The following is a description of a gene set: Human Gene Set: HP_HYPOTHALAMIC_HAMARTOMA The presence of a hamartoma of the hypothalamus. studied in species Homo sapiens Hypothalamic hamartoma, and this is the list of marker genes: VPS16, TOPORS, TMEM231, CPLANE1, GLI3, TIAM1, KIAA0753, SIX6, SOX2, OFD1, MAN2C1, KIF7, PDE6D, SMO, FAM149B1, TMEM216, TCTN3